The following is a description of a gene set: Human Gene Set: GOBP_EMBRYONIC_CAMERA_TYPE_EYE_FORMATION The developmental process pertaining to the initial formation of a camera-type eye from unspecified neurectoderm. This process begins with the differentiation of cells that form the optic field and ends when the optic cup has attained its shape. species: Homo sapiens, and this is the list of marker genes: ALDH1A3, WNT16, FRS2, PAX2, WNT5A, SOX11, TFAP2A, STRA6, PROX1, TWIST1, PHACTR4